Given this list of marker genes FLRT3, HNRNPA1, PDGFRB, CDKN1B, CTSK, RIN2, KIF1A, FBLN5, TNFRSF11A, POT1, WRAP53, SERPINF1, KDM1A, ALK, CYP27A1, LBR, WNK1, KIT, DKK1, CHEK2, FOXE1, GATM, ACVR1 (NCBI Gene Id 90), TACR3, KDELR2, CHD7, TET2, EFEMP2, ATL3, RUNX2, CCND1, GK, IDH1, TAPT1, ASXL1, MESD, TIMM8A, FGF8, ZNF469, HS6ST1 (heparan sulfate 6-O-sulfotransferase 1), PLOD3, TRIP4, PANK2 (pantothenate kinase 2), TINF2, RETREG1, ANO5, ATP7B, ZFHX2, COL2A1, NDUFAF6, CHD6, PTEN (NCBI Gene Id 8037), IDH2, LIN28B, MPV17, SATB2, LTBP1, DKC1, SPTLC1, RB1, TYROBP, LMOD3, IL6ST, TP53, CDKN1A (NCBI Gene Id 1026), TREM2, LPIN2 (NCBI Gene Id 9663), IER3IP1, B2M, SCN9A, PLOD2, SLC37A4, CHST3, MBTPS2, NDNF, KLHL40, MMP2, PLEKHM1 (NCBI Gene Id 9842), NRAS, TPM3, TERC, KLHL41, TMEM38B (transmembrane protein 38B), OCRL, ATP7A, CDKN2B, COPB2, CCDC134, RTEL1, ANTXR2, HGD, PRDM5, SPTLC2, P4HB, CLTCL1, ATL1, CASR, PHLDB1, DUSP6, CBL, MET, CCDC141, ZNF687, TENT5A, TERT, ACTA1, NEB, GNAS, TRPV6, TCIRG1, CA2, CREB3L1 (cAMP responsive element binding protein 3 like 1), COL1A2, YY1AP1, VCP, MMP14, WNT3A, MTAP, CRTAP, WNT1, FN1, SLC29A3, SEMA5A, CLCN5, IL17RD, SEC24D, FKBP10, SMS, GLE1, NHERF1, CBS, SOX9, NOTCH2, TNFRSF11B, CHRND, COL1A1, EHHADH, HESX1, MEN1, GNPTAB, RECQL4, KRAS, TYMS, MOGS, HACE1, HABP2, IFITM5, RUNX1, NOP10, CTNNB1, FEZF1, CYP2R1, SLC4A1, SP7, CDKN2C, PROKR2, UNC45A, TBCD, CTNND2, UROS, B3GAT3, B3GALT6, USB1, STAT3, GORAB, NGLY1, PHOX2B, P3H1, SMPD1, PROK2, KCNJ6, LMO1, PYCR1, HNRNPA2B1, B4GALT7, SRSF2, SEMA3A, SPRY4, CHRNA1, CLCN7, LRP5, GBA1, SPARC, MYH3, TRIP11 (thyroid hormone receptor interactor 11), NFIX, VDR, FGF17, NTRK1, IRX5, HBB, BMP1, FGFR1, DCC, SNX10, HRAS, NPM1, FZD4 (NCBI Gene Id 8322), LIFR, CHRNG, PARN, SLC34A3, SGMS2, MINPP1, WDR11, BRAF, SLC34A1, MYCN, ELP1, ARMC5, SLC4A2, BANF1, PTH1R, AGA, PPIB, NGF, RRM2B, SLC7A7, SOX10, COL11A1, TNFSF11, NHP2, CYP27B1, CTC1, ALPL, ANOS1, AGXT, SCARB2, ASCC1, SQSTM1, here is a description of the gene set: Human Gene Set: HP_INCREASED_SUSCEPTIBILITY_TO_FRACTURES Increased susceptibility to fractures An abnormally increased tendency to fractures of bones caused by an abnormal reduction in bone strength that is generally associated with an increased risk of fracture. species: Homo sapiens